The following is a description of a gene set: electronically inferred by orthology from the curated human pathway This event has been computationally inferred from an event that has been demonstrated in another species.<p>The inference is based on the homology mapping from PANTHER. Briefly, reactions for which all involved PhysicalEntities (in input, output and catalyst) have a mapped orthologue/paralogue (for complexes at least 75% of components must have a mapping) are inferred to the other species. studied in species Mus musculus Reactome Pathway: MyD88:MAL(TIRAP) cascade initiated on plasma membrane part of: Toll Like Receptor 4 (TLR4) Cascade; Toll Like Receptor TLR1:TLR2 Cascade; Toll Like Receptor TLR6:TLR2 Cascade, and this is the list of marker genes: Nfkb2, Tab3 (NCBI Gene Id 66724), Ppp2r5d, Rela, Casp8, Mapk3, Ubb, S100b, Nfkbib, Mapk11, Mapk8, Rps27a, Map2k4, Hmgb1, Ube2v1, Nfkb1, Ecsit, Irak1, Map2k3 (NCBI Gene Id 26397), Rps6ka5, Cul1, Ppp2r1b, Tab2, Map2k6, Mapk14, Tab1, Tirap (NCBI Gene Id 117149), Tifa, Ager, Mapk7, Nkiras1, Jun, Peli2, Nlrc5, Ikbkb, Map2k7, Nlrx1, Map3k8, Lrrc14, Dusp6, Vrk3, Fos, Dusp7, Mapk9, Ube2n, Nfkbia